Given this list of marker genes Bgn, Dse, Dcn, Cspg5, Chst15, Ust, Dsel, Chst14, here is a description of the gene set: This event has been computationally inferred from an event that has been demonstrated in another species.<p>The inference is based on the homology mapping from PANTHER. Briefly, reactions for which all involved PhysicalEntities (in input, output and catalyst) have a mapped orthologue/paralogue (for complexes at least 75% of components must have a mapping) are inferred to the other species. part of: Chondroitin sulfate/dermatan sulfate metabolism species: Mus musculus Reactome Pathway: DS-GAG biosynthesis electronically inferred by orthology from the curated human pathway